The following is a description of a gene set: Any process that stops, prevents or reduces the frequency, rate or extent of plasma membrane bounded cell projection assembly. studied in species Mus musculus Mouse Gene Set: GOBP_NEGATIVE_REGULATION_OF_PLASMA_MEMBRANE_BOUNDED_CELL_PROJECTION_ASSEMBLY, and this is the list of marker genes: Evl, Limk2, Yap1, Tesk1, Akt1, Odf2l, Tchp, Arhgap24, Luzp1 (leucine zipper protein 1), Cdk10, Rap1gap, Actr3, Nrxn1, Evi5l, Arhgap44, Gdi2, Slit2, Abi3, Cfl1, Hrg, Trim32, Mak, Cep97, Capzb, Tacstd2, Plxnb3, Rab3ip, Tbc1d7, Ccp110, Mphosph9, Lima1, Kif24, Prkcd, Lpar1, Ccl21a, Pfn2, Wdr44, Dnm2 (dynamin 2), Marchf7, Stap1, Kank1, Tbc1d30